The following is a description of a gene set: from publication Zwang Y, Sas-Chen A, Drier Y, Shay T, Avraham R, Lauriola M, Shema E, Lidor-Nili E, Jacob-Hirsch J, Amariglio N, Lu Y, Mills GB, Rechavi G, Oren M, Domany E, Yarden Y (PMID 21596316) studied in species Homo sapiens Normal cells require continuous exposure to growth factors in order to cross a restriction point and commit to cell-cycle progression. This can be replaced by two short, appropriately spaced pulses of growth factors, where the first pulse primes a process, which is completed by the second pulse, and enables restriction point crossing. Through integration of comprehensive proteomic and transcriptomic analyses of each pulse, we identified three processes that regulate restriction point crossing: (1) The first pulse induces essential metabolic enzymes and activates p53-dependent restraining processes. (2) The second pulse eliminates, via the PI3K/AKT pathway, the suppressive action of p53, as well as (3) sets an ERK-EGR1 threshold mechanism, which digitizes graded external signals into an all-or-none decision obligatory for S phase entry. Together, our findings uncover two gating mechanisms, which ensure that cells ignore fortuitous growth factors and undergo proliferation only in response to consistent mitogenic signals. Genes repressed in the time interval between two pulses of EGF in 184A1 cells (mammary epithelium). Human Gene Set: ZWANG_EGF_INTERVAL_DN, and this is the list of marker genes: SELENOM, TPD52L1, KDM5B, GABARAP, ZNF585A, TFAP2C, FTH1P4, IFT172, CCDC181, CYB5D2, CHRNA7, IKZF5, TNFSF10, EIF3A, ZC4H2, BCL9, ING4, KLF9, WNT9A, RPAIN, RETREG3, KLF3, RPS6KA5, PLAU, RN7SL516P, MXD3, NDUFS8, TBC1D2B, MAP3K12, RNF141, SLPI, MBP, RNA5SP440, PLAAT4, ENSG00000238326 (NCBI Gene Id 124901197), PYCARD, FGD4, CDC42BPG, ANKRD11, PSCA, ABTB2, KCNS3, SCAPER, BCAR3, RN7SKP129, SOX4, FTHL17, EHF, ZC3H12A, CLN3, CD248, SYT8, NOB1, PPDPF, RNU6-647P, PHACTR3, MARCHF9, PIH1D2 (NCBI Gene Id 120379), ARSA, TOMM40L, HOXA5, CDK9, FYB1, SFT2D3, GIGYF1, JUNB, FNBP1L, IRX3, EMP2, LARGE2, JAG2, RING1, CLDN7, JMY, DAAM1, GJB3, AR, ST6GAL1, IFIT1, INAVA, RIPK4, HOXA-AS2, RN7SKP161, SIN3A, FBXO2, RNU6-702P, CFAP69 (NCBI Gene Id 79846), KLF10, OVOL2, AKAP9, MMP28, GABRB1, PSEN2, SPSB1, RNU6-878P, HCP5, CPEB3, YPEL3, ZFP36, RPL10P3, SOX7, DELE1, SNORD56B, TMEM165, RN7SKP250, MED28, NUDT2, SERPINE1, MATN2, TMEM125, ARRDC2, RPL12, DKK1, PIK3R1 (NCBI Gene Id 5295), ARL14, CXCR2, PDLIM4, IRF1, PLEKHH3, CORO6, LINC01126, TFCP2L1, GABBR1, TLCD1 (TLC domain containing 1), HCFC1R1, MXI1, NDUFS7, REEP4, OR10R3P, RNA5SP403, SPATA13, FAM131B, CDIP1 (NCBI Gene Id 29965), SNORA70, AHNAK2, RBMS1P1, RNU6-600P, BTG1 (BTG anti-proliferation factor 1), PLD1, CXXC5, ARHGAP24, DAPK1, MXRA7, RALGDS, TOMM34, HFE, PTTG3P, CITED4, URB1-AS1, AGFG2, MT-CYB, RHOD, CA5B, ELF3, IRF2BPL, RNU4-2, EIF4A1, KIAA1191, PARD6B, TMEM101, CRACR2A, TMSB4XP2, MRTFA, RN7SKP71, RNU4-53P, LY6E, TICAM1, CASZ1, RN7SL368P, ARMC7, TIMP3, LRCH2, RN7SKP231, PRKCD, GRB7, VTRNA3-1P, NDUFAF3, TPP1 (NCBI Gene Id 727719), LAMA5, AKAP13, RAB25, HES1, FTMT, KAT6B, RNF44, AP4M1, GLRX, PAPPA-AS1, RNASE7, DUSP10, CA2, KLF8, MINDY1, KRT12, AATK, OSR1, ZNF608, ATOSA, SREBF1, TESK2, RTKN, RNA5SP172, NINJ1, MADD, C1orf210, TMEM179B, PHLDB1, NOS2 (nitric oxide synthase 2), CEP68, ARHGEF37, OSBPL7, PLEKHA7, RHOB, HOXA1, HIGD2A, KLK10, CDC42EP4, UNC5B, CCNL1, TRERF1, JADE2, TMEM138, SNAI2 (snail family transcriptional repressor 2), TMEM256, ATOH7, PNPO, CEBPB, SAMSN1, LLGL2, DAB2IP, ETFDH, ACAP1, BMP4, KCTD11, METTL23, ZBTB11-AS1, DAPK3, ABHD8